The following is a description of a gene set: Human Gene Set: HP_ABNORMAL_PELVIS_BONE_MORPHOLOGY studied in species Homo sapiens Abnormal pelvis bone morphology, and this is the list of marker genes: EXT2, FGFR2, DYM, B3GLCT, RSPRY1, ERCC8, ERCC6 (ERCC excision repair 6, chromatin remodeling factor), IDUA, COL11A2, EXT1, BGN, POR, VAC14, BMPER, MBTPS2, TRIP11, PCNT, ATP7A, FIG4, TRPV4, PTH1R, LEMD3